Given this list of marker genes ALG8, here is a description of the gene set: Reactome Pathway: Defective ALG8 causes CDG-1h part of: Diseases associated with N-glycosylation of proteins species: Homo sapiens The probable dolichyl pyrophosphate Glc1Man9GlcNAc2 alpha-1,3-glucosyltransferase (ALG8) normally adds the second glucose moiety to the lipid-linked oligosaccharide precursor (LLO aka N-glycan precursor) which is required for subsequent N-glycosylation of proteins. Defects in ALG8 can cause congenital disorder of glycosylation 1h (ALG8-CDG, CDG-1h; MIM:608104), a multisystem disorder characterised by under-glycosylated serum glycoproteins. ALG8 deficiency is accompanied by an accumulation of the N-glycan precursor (Glc)1 (GlcNAc)2 (Man)9 (PP-Dol)1. CDG type 1 diseases result in a wide variety of clinical features, such as defects in the nervous system development, psychomotor retardation, dysmorphic features, hypotonia, coagulation disorders, and immunodeficiency.